Given this list of marker genes SCN1B, NABP2, ARL4A, CHST9, PHOX2B, NEUROD2, SULF1, EHD4, ELP5, JADE1, NUMBL, LIMA1 (LIM domain and actin binding 1), MAP7, DUSP10, TFAP2D, HOXA11, DDAH2, ACLY, ST3GAL2, ARPC1A, SOX12, B3GALT2, UBQLN4, ABHD16A, DAPK1, MUSK, PHACTR3, TCF12 (NCBI Gene Id 6938), TRIM3, PRMT3, OPTC, BRME1 (break repair meiotic recombinase recruitment factor 1), CDC42EP4 (NCBI Gene Id 91740), MRPL58, SOBP, PLCB1, CD81, CPNE9, UBXN10, GLDN, INMT, CADM2, FGF9, FMNL3, KCNQ1DN, KLHL35, TMPRSS11F, C3orf20, FGD4, HOMEZ, C1QTNF4, DCX, MOAP1, RHOH, GABRA6, BCL6B, SERPINI1, PDIA6 (NCBI Gene Id 10130), UBE2E4P, FBXO16, NHLH1, RAB27A, ATP13A1, MRPL11, SEL1L3, HTR7, ZNF516-DT, RNF182, IKZF2 (NCBI Gene Id 51173), HID1, TFDP2, PTGR3, KLHL18, NXPH4, SEMA6D, INKA1, NSD1, DMD, SMAD3, NAA15, ARHGAP22, TNFAIP8, FBXO36, SELENOM, HECTD1, RNF19A, STAG2, MAP1A, EPHB2, CD79B, ASB4, PDCD10, SHOX2, LRRC42, CPE, DARS1, TMEM59L, HSD11B1, FOSB, ELMO1, CDK19, RRAS2, PCDH12 (protocadherin 12), ATP8A1, ARHGEF38, CDK6, BHLHE22, KIF9 (kinesin family member 9), HOXB6, RUNX1T1, ABCD2, ELAVL4, ACY3, SORBS1, WWC1, NXPH3, PDE1A, MBD6, NHLH2, SLN, PDGFB, BCL11B, RIOK3, PYY2, HRK, MYL6B, ZBTB18, ZNF710, BANF2, FKRP, MYCLP1, MARK1, LIN28A, ZBTB20, SCARF2, PICALM, KDM4C, CTLA4, CCDC26, GFRA3, STAG1, RGS3, EFS, MBNL2, CDH23, DDIT3 (DNA damage inducible transcript 3), LAMTOR2, PRDM8, SOX5, NCKIPSD, ITGA8, GFI1, ZMYND8, GRID2, MSI1, STARD13, KLF8, MIR137HG (MIR137 host gene), PROK2, DNAH9, SAP30L (SAP30 like), TFAP4, KCNJ2, GFRA1, NEB, LINC02908, ARHGAP44, HAAO, SCGN, CDIN1, GABARAPL2, SWAP70 (NCBI Gene Id 23075), LEF1 (NCBI Gene Id 51176), HIVEP3, NPR2, NKAIN3, RAG2, PHF21B, SLC9A9, PI15, MYOCD, FNDC3A, SIM1, TSKU, ST6GALNAC5, C17orf58, FGF13, TJAP1, LIX1, CBFA2T3, ITGBL1, HTR2C, TRIM37, MACF1, RCAN2, GPD1, FAP, ZNF485, TP53INP2, BRPF1, ELL2 (NCBI Gene Id 22936), PDLIM4, AFF3, LRP5, TAFA1, APOBEC4, RASL11B (NCBI Gene Id 79093), STK3 (serine/threonine kinase 3), STRN4, C12orf54, FOXO4, ZNF821, SLC6A10P, NEUROD6, FOXP1, DMC1, MED13, TSPAN33, PBXIP1, KERA (keratocan), DLL4, ATOH7, PAK3, ARSG, ZFP36L1, DDAH1, FOXP2, FLNC, NDUFA4L2, ADGRL2, HEXIM2, PYY, KCTD15, TMEM71, HOXA1, FIBCD1, TTN, NAP1L1, FRMD6, SH3KBP1, ZFPM2, EYA3, RCOR2, MID1, FOXB1, GTDC1, TAC1, ELF4, PRG4, ZNF513, TPH2, C7orf33, NUFIP2, ASB2, CTDNEP1, E2F7, RP1L1, HSPB6, KIRREL2 (kirre like nephrin family adhesion molecule 2), ANGPTL1, LVRN, PNMA1, BRD4, LTBP1, SERTAD4, CLVS1, here is a description of the gene set: Human Gene Set: TAL1BETAITF2_01 studied in species Homo sapiens Genes having at least one occurrence of the motif NNNAACAGATGKTNNN in the regions spanning 4 kb centered on their transcription starting sites. This matches the TAL1, TCF4 transcription factor binding site V$TAL1BETAITF2_01 (v7.4 TRANSFAC).